The following is a description of a gene set: studied in species Homo sapiens Human Gene Set: CDP_02 Genes having at least one occurrence of the motif NWNATCGATTANYNN in the regions spanning 4 kb centered on their transcription starting sites. This matches the CUTL1 transcription factor binding site V$CDP_02 (v7.4 TRANSFAC)., and this is the list of marker genes: DCX, MEIS1, EPHA3, LCP1, HOXB8, DGKB, BIRC8, WDR12 (NCBI Gene Id 55759), CPEB4, SLC6A9, PITX2, ZNF689 (zinc finger protein 689), KIF1B, CDCA7, MARCKS, NDST4, CACNA2D3, TOB1, LRCH2, HOXB7, ANKRD2, POU3F4, BHLHE22 (basic helix-loop-helix family member e22), MYPN, LSAMP, PCGF2 (polycomb group ring finger 2), ACVR2A, SREBF2, MROH2B, HCN1, CDH9, MINDY1, PTGS2, SPACA9, HNRNPA2B1, PDZRN4, GNAO1, DOCK4, CARF, GNAQ (NCBI Gene Id 2776), MYH10, COLCA1, PHACTR3, AK8, LRATD2, SEMA6A, TSHZ2, SLC1A3, GRIA3, RBFOX1, SP8, OTX1, PTMA, GBX2, PKD2L2, IL1RAPL1, IKZF2, SRPK2, CCDC60, CCDC91, CEACAM19, SLC5A10, ATXN7L1, PRKAG1, RUNX1T1, TCF4, FOXD3, MEF2C, HOXA7, A1BG, PPM1L, LINC01597, GTF2IRD1, UCKL1, SYT1, TFR2, LIF, TMEM255A, SIAH3, JARID2, DUSP10, GC, MAB21L2, OGG1, SALL1, DACH1, SIX1, SEMA5B, CADM1, ETV4, CS, HOXA2, MBNL1, HOXA11, RPA3, NRXN3, GINS3, ERG, CCND2, GPM6A, ADGRL2, SOX9, MLN, FGF9, HNF4G, CNIH1, SLITRK2 (NCBI Gene Id 84631), STAG2, PTF1A, TBX3, TFAP2D, GPX1